Given this list of marker genes Skida1, Atg10, Eif4g3, Sema3a, Smarca2, D330041H03Rik, Gm19774, Gtf3c6, 5930403N24Rik, Gm11228, Tle6, 2900052L18Rik, Gm13652, Med22, 2600014E21Rik, Tmem176b, Rnu11, H3c6, Sh3gl1, Snord55, Rmi1, Gm15420, Snord3a, Gtpbp1, Snora7a, Tbx18, 2610005L07Rik, Mir7238, Rps14, Hoxa9, Snord58b (small nucleolar RNA, C/D box 58B), Ppm1b, Rps10, 1700028E10Rik, Gm23205, 1110020A21Rik, Malat1, Fmc1 (formation of mitochondrial complex V assembly factor 1), Rps17, Rpl13, Ankrd10, Rps8, Gm23301, Rpl7a, Nf1, Rpl5, Marcks, Hnrnpk, Tmem176a, Cct4, Hexim1, mt-Tv, Marf1, Gm22589, Rpl11, Rpl17, Tmem259, Rhobtb1, Rps6, Eef2, Ttc32 (NCBI Gene Id 75516), Knl1, Gm26330, Rpl32, Rbm25, mt-Rnr2, Ube2i, Csnk1d, Tle1, Ddx39b, Snord68, Eif3f, Jazf1, C630043F03Rik, Tle4, Gm23969, here is a description of the gene set: studied in species Mus musculus Mouse Gene Set: LMX1B_TARGET_GENES from publication Yevshin I, Sharipov R, Kolmykov S, Kondrakhin Y, Kolpakov F (PMID 30445619) Genes containing one or more binding sites for (Lmx1b) in their promoter regions (TSS -1000,+100 bp) as identified by GTRD version 20.06 ChIP-seq harmonization.